Given this list of marker genes CHD4, VPS35, NLGN2, NLGN1, SLITRK3, SNAPIN, here is a description of the gene set: species: Homo sapiens A process that is carried out at the cellular level which results in the assembly, arrangement of constituent parts, or disassembly of a terminal button. A terminal button is the terminal inflated portion of the axon, containing the specialized apparatus necessary to release neurotransmitters. Human Gene Set: GOBP_TERMINAL_BUTTON_ORGANIZATION